The following is a description of a gene set: Any process that modulates the frequency, rate, or extent of leukocyte mediated immunity. studied in species Homo sapiens Human Gene Set: GOBP_REGULATION_OF_LEUKOCYTE_MEDIATED_IMMUNITY, and this is the list of marker genes: C17orf99, ARRB2, DHX36, TLR4, SH2D1A, YWHAG, MR1, KLRC4, IL2, MLH1, KLRC4-KLRK1, KMT5C, RIGI, SHLD3, IL4R, RAC2, FCER2, CCR2 (C-C motif chemokine receptor 2), C3, IL18RAP, IL13, KLRC1, TREM2, RASGRP4, ITGAM, CYRIB, ZBTB1, IL12RB1, WAS, ULBP3, USP5, PTPRC, RABGEF1, CRTAM, KLRD1, GATA1, NDFIP1, VAMP7, TNFRSF1B, MICA, CXCL6, RAET1E, PLCG2, IL23A, PMS2, MAP3K7, SLAMF6, RIPK3, IL18, FES, HLA-B, AHR, SECTM1, SH2D1B, IL27RA, JAK3, CR1, HMGB1, CLEC7A (C-type lectin domain containing 7A), GATA3, C4BPB, RSAD2, CX3CR1, CD81, TICAM1, KMT5B, TP53BP1, NECTIN4, KLRK1, TRAF6, CD96, XCL1, ZP3, RASGRP1, CD177, KIT, IL4I1, CLCF1, CD1B (NCBI Gene Id 910), LAMP1, STXBP2, APLF, LEP, EXOSC3, FCGR2B, PVR, CR2, NOD2, TGFB1, LILRB4, GRB2, ARG1, IL18R1, IL6 (interleukin 6), IL1B, ULBP2, CLEC12B, AZGP1, LTA, TLR9, TNFSF13, FZD5, DENND1B, MSH2, NCR1, FOXF1, HLA-A, HLA-DRB1, CRK, SNX4, KLRC2, TAP2, SERPINB4, HLA-H, ICAM1, HLA-E, BST2, PARP3, IL12A, TIGIT, NLRP3, PPP3CB, HLA-C, CLC, SLC22A13, HAVCR2, CD1A, FUT7, SUSD4, HSPD1, MAVS, DNASE1, IL13RA2, SUPT6H, SPN, IL4, FOXJ1, HLA-DRA, PRKCZ, KIR2DL4, TYROBP (NCBI Gene Id 7305), IL10, TRPM4, PLA2G3, KLRB1, STAT5A, DNASE1L3, ULBP1 (NCBI Gene Id 80329), STX7, TFRC, GAB2, RAET1G, LILRB1, SPHK2, STAP1, DUSP22, CD84, CD274, BTK, POMC, FCER1G, DDX21, HLA-G (major histocompatibility complex, class I, G), CD55, IL1R1, IL20RB, CD28, AP1G1, SHLD1 (shieldin complex subunit 1), PIK3R6, FCGR1A, PAXIP1 (NCBI Gene Id 22976), CD80, HLA-DRB3, TNFSF4, NCKAP1L, C4BPA, STXBP1, MAD2L2, FOXP3, SERPINB9, CALHM6, CD40, ARID5A, SYK, PRKAA1, FADD, MAPK3, AGER, SLC15A4, TNF, UFL1, VAMP8, STAT5B, IL7R, IL23R, ADGRE2, ATAD5, ADORA2B, SLAMF1, DDX1, NOS2, CLNK, RIF1, NSD2, NECTIN2 (NCBI Gene Id 5819), MALT1, CD160, CD1E, ITGB2, BCR, IL21, FGR, SMAD7, HMCES, IFNA2, TLR3, CD1C, RAET1L, LYN, SPI1, IFNB1, CADM1 (NCBI Gene Id 337934), CD226, TBX21, KLHL22, P2RX7, TRAF2, HFE, CR1L, SHLD2, FBXO38, INPP5D, UNC13D, F2RL1, LAG3 (NCBI Gene Id 3902), CAMK4, GATA2, CD46, CD7, B2M, PDPK1, STX4, PRAM1, VAV1, EXOSC6, HLA-F, CEACAM1 (CEA cell adhesion molecule 1), BCL6, CD1D, IL12B, LGALS9, CLEC4G, KLRC3, STAT6, PTPN6, SCIMP, HPX, PDCD1, CD300A (NCBI Gene Id 11314), SASH3, FERRY3, NCR3